The following is a description of a gene set: species: Mus musculus Mouse Gene Set: chrYB, and this is the list of marker genes: Gm21787, Gm21801, Gm29426, Gm21588, Gm20798, Gm29386, Gm29023, Gm29333, Gm28776 (predicted gene 28776), Gm29027, Gm29360, Gm29215, Gm28504, Gm20898, Gm21765 (predicted gene, 21765), Gm28517, Gm29656, Gm28597, Gm20922, Gm21774, Gm20795 (predicted gene, 20795), Gm36782, Gm29286, Gm21739, Gm29079, Gm29413, Gm28211, Gm21735, Gm28850, Gm29652, Gm21810, Gm29285, Gm29412, Gm20835 (NCBI Gene Id 108168509, predicted gene, 20835), Gm28091, Gm21201, Gm29498, Gm29165, Gm28312, Gm20832, Gm21896, Gm21835 (predicted gene, 21835), Gm28371, Gm28468, Gm21756, Gm21626, Gm28786, Gm21599, Gm28212, Gm20838, Gm28464 (NCBI Gene Id 102638415), Gm21783, Gm21799, Gm20793, Gm21805, Gm21898 (predicted gene, 21898), Gm28617, Gm20901, Gm28770, Gm28337, Gm21872, Gm20827, Gm29081, Gm21729, Gm21647, Gm29280, Gm21865, Gm20905, Gm28886, Gapdh-ps15, Gm21241, Gm21916, Gm29029, Gm28773, Gm20853, Gm28765, Gm20799, Gm29276 (NCBI Gene Id 101055773), Gm29411, Gm21795, Gm20855 (NCBI Gene Id 108168545), Gm29495, Gm21745, Gm29531, Gm29024, Gm20738, Gm21633, Gm21184, Gm20896, Gm21856, Gm28280, Gm28596, Gm20897, Gm28260, Gm29645, Gm28518, Gm28522